The following is a description of a gene set: Human Gene Set: REACTOME_TRANSLESION_SYNTHESIS_BY_Y_FAMILY_DNA_POLYMERASES_BYPASSES_LESIONS_ON_DNA_TEMPLATE studied in species Homo sapiens Translesion synthesis by Y family DNA polymerases bypasses lesions on DNA template, and this is the list of marker genes: POLI, RCHY1, RPA2, RFC3, POLH, POLD2, UFD1, PCNA, UBA52, RFC4, RFC1, USP43, UBC, UBA7, VCP, POLD4, REV1, POLE4, ISG15, NPLOC4, RPA1, TRIM25, POLE, SPRTN, RPA3, MAD2L2, RFC2, POLE2, POLD3, REV3L, POLK, RFC5, UBE2L6, USP10, POLD1, PCLAF, POLE3, RPS27A, UBB